The following is a description of a gene set: species: Mus musculus Any process in by an organism or tissue maintains a population of neuronal stem cells. Mouse Gene Set: GOBP_NEURONAL_STEM_CELL_POPULATION_MAINTENANCE, and this is the list of marker genes: Aspm, Prox1, Mapk8, Pcm1, Fancc, Yme1l1, Fancd2, Hes5, Mcph1, Mmp24, Wdr47, Notch1, Rest, Wdr62, Dll1, Igf2bp1, Ss18, Jag1, Srrt, Hook3, Fut10, Cdh2, Foxo1, Sct, Foxo3, Hes1, Prrx1 (paired related homeobox 1), Sox2